The following is a description of a gene set: Genes having at least one occurrence of the motif NNNTAATTNNCATTANCN in the regions spanning 4 kb centered on their transcription starting sites. This matches the CART1 transcription factor binding site V$CART1_01 (v7.4 TRANSFAC). species: Homo sapiens Human Gene Set: CART1_01, and this is the list of marker genes: ZNF148, PPM1E, HPSE2, NOS1, GABRA6, BBX, SLC16A9, IMMP1L, ESRRG, HOXA5, TMEM178A, MKS1, NPHP4, CBL, PTCH1, UNC13B (unc-13 homolog B), PRDM10, PLEKHA6, ZFPM2, PHOX2B, NOL4, PELI2, ANKS1B, ZNF362, RIMS2, FOXN3, MYH1, RFXANK, SMARCA2, SKA2, JPH3, MEF2C, FGF13, PPP1R2B, FEZF2, ROR1, HOXB7, ELOA, ZDHHC21, DNASE1L3, CNTNAP4, CADM2, CHRDL1, BNC2, ARL4C, EYA1, LMO3, ARPP21, CDH6, WARS2, PDGFRA, PDGFC, SALL3, GBX2, ZIC3, ITPR3, FOXP2, ZNF423, PAK3, TRPV1, MOXD1, CRTAC1, ASIC1, TFAP2D, TSPEAR, DLL4 (NCBI Gene Id 54567), KLHL13, BCL11A, KRT2, PRKAG1, KRT84, SEC14L3, EFEMP1, IRX2, GARRE1, ADAM11, CDKN2C, STC1, RUNX1T1, ZC2HC1C, NECTIN3, MSRB3, MBNL2, PRRX1, ACADSB, BACE2, PRDM1, PRPF38B, GRM8, ABHD17B, CHD2, SALL1, KIRREL3-AS3, MIR9-1HG, MID1, ASIC2, LRFN5, LGALS12, LOXHD1 (NCBI Gene Id 125336), PRUNE2, TMEM255A, IRX2-DT, HOXB5, CEP290, THAP6, PTPRC, HSD3B7, ACBD5, MAL2, TAFA1, CABLES1, TNRC6A, TMEM117, ZNF219, ATP8B1, SPTB, CNMD, ERG, NOL4L, GPX1, FYN, SLITRK5, YARS1 (tyrosyl-tRNA synthetase 1), RCHY1, CREB5, STOML2, LRRC15, ELF5, TCP11L2 (t-complex 11 like 2), PCF11, NPTX2, ENSG00000291228 (novel transcript), WNT3, NFIX, HESX1, SERTAD4 (SERTA domain containing 4), TMEM132E-DT, CLDN4 (NCBI Gene Id 1364), HOXA11, EDC4, GOLGA1, DENND1B, PAPPA, PCDHB15 (NCBI Gene Id 56121), C1GALT1C1, SKIDA1, ARHGEF10L, SOX5, REEP4, ZNF281, HP1BP3, SOX4, NETO1, HIPK3, RBFOX1, GPR85, KYNU, SLC26A3, TEAD3, PRDX2, NRAS, CDKL5, OGG1, RLIM, EPHA7, RCAN1, MTUS1, CFL2, ZBTB18, ELP4, KRT26, MYH2, LRR1, SEPHS1, OTP (orthopedia homeobox), CLCA3P, RPS19, MPPED2, C1QTNF6, ANAPC15, CYP46A1, TACSTD2, HOXA3, LHFPL1, TRAF3 (TNF receptor associated factor 3), EN1, NPVF, UBE2E4P, HOXB3, PDZRN4, OTX2, ARRB1, CALB2, PTMA, POU2F1, BAMBI, ACACA (acetyl-CoA carboxylase alpha), HOXB6, MYT1, PATL1, KCTD15, RAB6A, NEUROD6 (NCBI Gene Id 63974), IKZF5, MEIS2, RFX3, MAP2K5, PRSS12, FOXB1, CNTLN, DLG2, SREK1, POGZ, TTR, LMO4, BCL6, RAB2B, WDPCP, MDP1, PTF1A, CLRN1, CALD1, TBC1D21, BEND4 (NCBI Gene Id 389206), OTUD7B, HYCC1, MIR137HG, UBR5, PBX1